Given this list of marker genes MRPS5, ZC3H15, TRAP1, FXN, CHPT1, NUP188, MRPS18C, MRPL50, MED24, ALDH9A1, UTP18, CLPB, SNF8, MAGT1, RPP14, TTC7B, RAB34, EIF4A3, PYCR1, SMARCAD1, EIF1AY, PRADC1, SNAPC3, LTV1, LSG1, RBM19 (RNA binding motif protein 19), HDLBP, CBR4, DMAP1, UBR7, CUL1, TYW1 (tRNA-yW synthesizing protein 1 homolog), ASB3, SLC66A1, ZNF235, PRR15, ATP5PB, NENF, SNX10, CCL22, ORC4, THAP2, MCUB, PRPS1, ELOVL1 (ELOVL fatty acid elongase 1), ACLY, PDK3, NUP88, TMEM14C, ACTG1, HLCS, SURF2, TXNDC5, JMJD8, C8orf82, MRPL55, ELK3, FMC1, COQ8B, PXMP2, SDHA, GTF2H3, SARNP, CAPS2, CEP290, ELP3, XPO1, TM2D3 (TM2 domain containing 3), TXNRD2, TREX1, GTF3C4, TSEN15, MEA1, MYO7A, ACP2, PFDN1, PWP2, NUTF2, CERS2, TFG, CD274, NXT1, ARMC1, FAM86B2 (NCBI Gene Id 653333), CCDC107, SELENOF, ANP32B, ZMPSTE24, TMEM33, PHACTR2, C2CD2L, CCN1, HSPH1, HNRNPU, TXNDC12, HNRNPC, CPPED1, PTPA, HEATR6, ZNF239, ALPL, KIFC1, MRPL54, CENPA, PTDSS2, IL15RA, RSRC1, PTGER4, GJC1, GUK1, SPTLC1, PEX7, SLC16A1, GPT2, MAP3K8, ATPAF2, SPRYD7, ABHD4, HDAC7, SDC1, CEP57L1, NCAPH2, SMN1, BRCC3, RBM4, GSTM3, POLR2G, SEC23IP, LAG3, C8orf33, AFG2A, EEF1D, CFAP97, PDIA6, FDXR, ISYNA1, CUTC, GTF3C5, PYCR2, SH3BP2, SLC30A6, UBAC1, VPS45, FANCG, COA6, PARN, FAM20B, PNN, PDE6D, NSUN2, TPRKB, CYP51A1, RCC1L, ANAPC13, MPZL2, MPP7, LARP1, MED31, DDOST, FOXD2, MTIF2, NEIL3, ATP1A1, HMGB2, MRPL46, AMPD2, ETV6, POLR1C, POLR2E, ARPC5L, NAMPT (nicotinamide phosphoribosyltransferase), EMG1, IRS4, MIS18A, EHD4, NME6, TMEM186, BLMH, SNRPB2, LPCAT1, NCBP2, BNIP1, CBX6, MED28, TMEM184C, PARK7, PIGU, ALDOA, ATP5MC3, MRPS21, HMGB1, SF3A2, PRKCI, FKBP1A, RPP25L, INTS14, XCL1, BHLHE40, RPIA, CHAC2, here is a description of the gene set: Human Gene Set: GSE15330_MEGAKARYOCYTE_ERYTHROID_VS_GRANULOCYTE_MONOCYTE_PROGENITOR_IKAROS_KO_UP from publication Ng SY, Yoshida T, Zhang J, Georgopoulos K (PMID 19345118) Regulation of lineage potential and transcriptional priming by Ikaros. New insight is provided into a bivalent regulation of lineage priming in the HSC and its lympho-myeloid restricted progeny the LMPP by the lymphoid lineage-determining factor Ikaros Whereas Ikaros is responsible for the activation of a cascade of lymphoid expression programs and for the establishment of lymphoid potential from the HSC to the LMPP it is also responsible for the repression of stem cell and erythroid genetic programs that are incompatible with further lineage restrictions emanating from the LMPP Genes up-regulated in IKZF1 knockout: megakaryo-erythrocyte progenitors versus granulo-monocyte progenitors. studied in species Homo sapiens